Given this list of marker genes Mospd2, Brd1, Slc4a10, Unc5c, Dclre1c, Mlf2, Phf11, Klf12, Ube2k, Cand2, Iqcg, Fgf13, Lrp3, Zbtb37, Pkia, Zfp600, Cd24a, Clhc1, Aggf1, Chst2, Usp16, L1cam, Faxc, Dgat2l6 (NCBI Gene Id 668257), Trmt10a, Zdhhc16, Mybl1, Fgf12, Aurkb, Hmbox1, Camk1d, Zfp493, Gucy1a2, Tbl2, Mmd, Lrrn1, Mest, Bzw1, Pcgf3, Rmi1, Kcnk10, Lrrc30, Aff1, Slc39a10, Syt1, Rassf4, Rex2, Fhl2, Bmx, Cntnap2, Crls1, Mbnl1, Prpf4b, Actl6a, Ncor1, Cdh13, Zfp830, Elavl2, Ikzf5, Prelid1, Gas2l3, Osgepl1, Zfp981, here is a description of the gene set: Mouse Gene Set: MIR_6908_5P from publication Chen Y, Wang X (PMID 31504780) Genes predicted to be targets of miRBase v22 microRNA mmu_miR_6908_5p in miRDB v6.0 with MirTarget v4 prediction scores > 80 (high confidence targets). studied in species Mus musculus